The following is a description of a gene set: A protein complex that interacts with the carboxy-terminal domain of the largest subunit of RNA polymerase II and plays an active role in transducing the signal from a transcription factor to the transcriptional machinery. The mediator complex is required for activation of transcription of most protein-coding genes, but can also act as a transcriptional corepressor. The Saccharomyces complex contains several identifiable subcomplexes: a head domain comprising Srb2, -4, and -5, Med6, -8, and -11, and Rox3 proteins; a middle domain comprising Med1, -4, and -7, Nut1 and -2, Cse2, Rgr1, Soh1, and Srb7 proteins; a tail consisting of Gal11p, Med2p, Pgd1p, and Sin4p; and a regulatory subcomplex comprising Ssn2, -3, and -8, and Srb8 proteins. Metazoan mediator complexes have similar modular structures and include homologs of yeast Srb and Med proteins. Human Gene Set: GOCC_MEDIATOR_COMPLEX species: Homo sapiens, and this is the list of marker genes: MED17, MED11, MED18, BCLAF1, MED23, MED12L, MED24, MED26, MED27, MED19, MED8, MED16, CCNC, MED10, MED12, BCLAF3, UXT, MED20, MED6, MED21, MED29 (NCBI Gene Id 55588), PPARGC1B, MED22, MED13L, MED7, MED9, MED28, THRAP3, MED25, HAVCR2, MED14, MED4, MED31, MED30, CDK8, MED13, NFE2L2, MED1